Given this list of marker genes TNFRSF17, SLC17A7, CTDP1, CREM, CHRNA5, MED22, ETV5, CSPG5, TACR3, KNG1, TSPYL5, KHDC4, TOMM40, TGIF2, EPHB2 (EPH receptor B2), PDYN, OLFM1, MAP3K9, ICAM1, GAL, RXYLT1, IFI6, TBXA2R, ADGRL1, GPR18, PSMD3, F2RL1, SPR, EEF1A2 (eukaryotic translation elongation factor 1 alpha 2), TMEM109, MCM7, MTF2, TFF3, CLTB, METTL3, FKBP4 (FKBP prolyl isomerase 4), E2F5, HTR7, MERTK, AGL, RAB27A, UNC13B, TSFM (NCBI Gene Id 10102), SNRPA1, MCM5, PPP3R1, RORA (NCBI Gene Id 6095), SNRPB, ZNF195, TERF1 (NCBI Gene Id 7013), ADGRG2, PPM1G, RAB33A, TSC22D4, ADARB1, E2F3, MSI1, FKBP1A, SF1, CHKA, BLMH, PLXNA2, SEC23B, SYNGR2, KBTBD11, AK4, GYG2 (NCBI Gene Id 8908), SLC25A4, ATP1B2, STAT5B, SYNGR3, CLPTM1, NFATC2IP, ABHD2, NR4A3, PRIM1, CXCL2, FOXA1, RAB6B, TESK1, CD83, EPCAM, TRAF3IP1, RRM2, UCP2, N4BP1, ST7, OCLNP1, WNT11, PAK2, CDC5L, TSPAN9, FGF9, SH3GL3, CDK2, MASP2 (NCBI Gene Id 10747), NELFA, ZHX2, NPTXR, ALDH1A3, RALGAPA1P1, KEAP1, PLEK, BRINP1, PARP2, GORASP1, NUP98, KMT2B, ABAT, LRP8 (NCBI Gene Id 7804), CXADR, CXCL8, MYOZ3, GRPEL1, BID, ATP6V0A1, GLS2, TAF5L, ZNF536, AGO2, PCGF3, BAZ1A, ME2, CAMK2G, BHLHE40, APEX2, HLTF, NEO1, BRMS1, TMEM265, RAB5C, DTNB, PHF8 (NCBI Gene Id 57793), RASGRP1, IPO13, COIL (NCBI Gene Id 96825), SLC29A1, ATP8A1, POU2F1, SS18L1, TRIP10, FZD5, ABLIM1, NFKBIA, PDIA4, IL17RA, here is a description of the gene set: from publication Browne EP, Wing B, Coleman D, Shenk T (PMID 11711622) studied in species Homo sapiens The effect of human cytomegalovirus (HCMV) infection on cellular mRNA accumulation was analyzed by gene chip technology. During a 48-h time course after infection of human diploid fibroblasts, 1,425 cellular mRNAs were found to be up-regulated or down-regulated by threefold or greater in at least two consecutive time points. Several classes of genes were prominently affected, including interferon response genes, cell cycle regulators, apoptosis regulators, inflammatory pathway genes, and immune regulators. The number of mRNAs that were up-regulated or down-regulated were roughly equal over the complete time course. However, for the first 8 h after infection, the number of up-regulated mRNAs was significantly less than the number of down-regulated mRNAs. By analyzing the mRNA expression profile of cells infected in the presence of cycloheximide, it was found that a minimum of 25 mRNAs were modulated by HCMV in the absence of protein synthesis. These included mRNAs encoded by a small number of interferon-responsive genes, as well as beta interferon itself. Cellular mRNA levels in cytomegalovirus-infected cells were compared to the levels in cells infected with UV-inactivated virus. The inactivated virus caused the up-regulation of a much greater number of mRNAs, many of which encoded proteins with antiviral roles, such as interferon-responsive genes and proinflammatory cytokines. These data argue that one or more newly synthesized viral gene products block the induction of antiviral pathways that are triggered by HCMV binding and entry. Genes up-regulated in primary fibroblast cell culture after infection with HCMV (AD169 strain) at 24 h time point that were not up-regulated at the previous time point, 20 h. Human Gene Set: BROWNE_HCMV_INFECTION_24HR_UP